Given this list of marker genes TOP1MT, WDTC1, RHBDL3, RCOR3, FBXW12, RNF123, GZMK, ERF (NCBI Gene Id 2077), DGKG, RHOBTB2, ITGA6, OR5D18, RNF151, CWF19L1, QSOX1, HPD, INPP5K, KCNMB2, CNR1, BACE1, ZNF598, TMCO6, FZD2, JOSD2, CLP1, DNAJB8, EXTL1, H1-4, HSPB2, MIB2, PMEL, CCDC198, HNRNPD (heterogeneous nuclear ribonucleoprotein D), DOC2B, ACADS, SLC17A1, AP4M1, CR2, HSD3B2, MRM1, DUSP16 (NCBI Gene Id 80824, dual specificity phosphatase 16), MAML1, GPR37, ALOX12B, KANK2, ARNT2, MAP4K4, RCAN2, ZNF146, SHISA2, HNRNPC, CBFA2T3, FXYD7, IL36RN, OLAH, SGCD, BUB1, DOK4, GDI1 (GDP dissociation inhibitor 1), KLC3, TMX2, THRA, WNT2B, LIPT1, NUP85, PRR13, LOXL1, CDKAL1, KRTAP3-1, ZFP30, MAP3K14, PRKAB1, ZNF239, OR11H4, CMTM8, PSD, EIF1AY, CD99L2, APOF, SLC17A6, STK19, SLC26A6, TRIM69, MYL1 (NCBI Gene Id 90307), LYPLA2, MLC1, PLA1A, SNX29, CHST15, RECQL4, TRMT1 (NCBI Gene Id 55621), GINS1, NCAPG, DGKA, IKZF2, TESMIN, DENND2D (NCBI Gene Id 79961), TRPV6, PPP2R5B, PWP2 (NCBI Gene Id 5822), GPRC5B, KRT79, ALDH1A1, COL3A1, PROZ, CAPN9, CYS1, MEF2B, RIN1, SEC22B (NCBI Gene Id 9554), SPMIP5, ADD1, GGT5, PCDH20, ABCB9, MRPL23, TFAP2C, FIBIN, BASP1 (brain abundant membrane attached signal protein 1), ATXN7, KRTAP8-1, PCDHB1, EPB41L3, RNF126, PGC, OR13J1, ACTR1A, SPP2, SDHAF2, ANGEL2, PAWR, UBQLN4, COL11A2, PTPN5, TNPO2, KRTAP15-1, RNF135, SALL4, COPS7B, CYP3A43, XCR1, IGF2-AS, CGA, CLCNKA, RSPO2, IZUMO1R, CDK12, MDFI, HPGDS, KLHL42, TNIP1, CREB3L4, DAB2IP, ACKR4, TMEM258, EBF1, MEIS1, OSCAR, ACOT2, EPOP, SERAC1, STAP2, CTSF, ARPC1B, FAM81A, MYOC, MYO6, IKBKB, CDK5RAP3, FBXL15, DENND5A, GPA33, CLIP1, ANKRD13C, SYN2, FSHR, SATB1 (NCBI Gene Id 6304), ARSG, MAP1LC3A, PLA2G5, SCML4, SLC45A2, DDR2, ZBTB48 (zinc finger and BTB domain containing 48), EN2, PRPH2, PLVAP, ADGRE5, PRKG1, SLC7A10, TNS2, NT5M, SPMIP10, SH3BP1, GGCX, ZNF426, GPATCH4, TPM2, TBX18, here is a description of the gene set: species: Homo sapiens mouse primary BMDCs were stimulated with tlr ligands and gene expression changes were profiled on Affymetrix arrays Human Gene Set: GSE17721_POLYIC_VS_CPG_0.5H_BMDC_UP from publication Amit I, Garber M, Chevrier N, Leite AP, Donner Y, Eisenhaure T, Guttman M, Grenier JK, Li W, Zuk O, Schubert LA, Birditt B, Shay T, Goren A, Zhang X, Smith Z, Deering R, McDonald RC, Cabili M, Bernstein BE, Rinn JL, Meissner A, Root DE, Hacohen N, Regev A (PMID 19729616) Genes up-regulated in comparison of dendritic cells (DC) stimulated with poly(I:C) (TLR3 agonist) at 0.5 h versus DC cells stimulated with CpG DNA (TLR9 agonist) at 0.5 h.